Given this list of marker genes APOC1, NR1H3, CETP, APOE, PLA2G7, MMP9, HBA1 (hemoglobin subunit alpha 1), ADAMDEC1, ENPP2, RARRES2, PTGDS, UBD, CASK, PLA2G2D, TIMD4, here is a description of the gene set: Human Gene Set: HE_LIM_SUN_FETAL_LUNG_C2_APOE_POS_M1_MACROPHAGE_CELL studied in species Homo sapiens APOE+ Mφ1 from publication He P, Lim K, Sun D, Pett JP, Jeng Q, Polanski K, Dong Z, Bolt L, Richardson L, Mamanova L, Dabrowska M, Wilbrey-Clark A, Madissoon E, Tuong ZK, Dann E, Suo C, Goh I, Yoshida M, Nikolić MZ, Janes SM, He X, Barker RA, Teichmann SA, Marioni JC, Meyer KB, Rawlins EL (PMID 36493756)